The following is a description of a gene set: The progression of the tricuspid valve over time, from its formation to the mature structure. species: Homo sapiens Human Gene Set: GOBP_TRICUSPID_VALVE_DEVELOPMENT, and this is the list of marker genes: HEY2, BMPR1A, TGFBR2, ADAMTS19, TBX20, ZFPM1, BMPR2